The following is a description of a gene set: Any process that stops, prevents, or reduces the frequency, rate, or extent of a T cell mediated immune response to tumor cell. Mouse Gene Set: GOBP_NEGATIVE_REGULATION_OF_T_CELL_MEDIATED_IMMUNE_RESPONSE_TO_TUMOR_CELL studied in species Mus musculus, and this is the list of marker genes: Ahr, Cd274, Muc4, Il4i1, Ufl1 (UFM1 specific ligase 1), Pdcd1